The following is a description of a gene set: Reactome Pathway: Defective TPMT causes TPMT deficiency studied in species Homo sapiens Methylation is a major biotransformation route of thiopurine drugs such as 6-mercaptopurine (6MP), used in the treatment of inflammatory diseases such as rheumatoid arthritis and childhood acute lymphoblastic leukemia. 6MP and its thioguanine nucleotide metabolites are principally inactivated by thiopurine methyltransferase (TPMT)-catalysed S-methylation.<br><br>Defects in TPMT can cause thiopurine S-methyltransferase deficiency (TPMT deficiency; MIM:610460). Patients with intermediate or no TPMT activity are at risk of toxicity such as myelosuppression after receiving standard doses of thiopurine drugs. Inter individual differences in response to these drugs are largely determined by genetic variation at the TPMT locus. TPMT exhibits an autosomal co dominant phenotype: About one in 300 people in Caucasian, African, African-American, and Asian populations are TPMT deficient. Approximately 6-10% of people in these populations inherit intermediate TPMT activity and are heterozygous at the TPMT locus. The rest are homozygous for the wild type allele and have high levels of TPMT activity.. part of: Metabolic disorders of biological oxidation enzymes, and this is the list of marker genes: TPMT